Given this list of marker genes ERI2, DSG3, KCNK2, UPF1, TMED7, SIPA1L1, SNRPD3, BBX, SCX, AKAP5, EPS8, SEC23A, SRCIN1 (SRC kinase signaling inhibitor 1), C3orf70, TNFSF13B (NCBI Gene Id 89794), ERC2, VPS41, GUF1, AVL9, ANKRD17, RAB42, SCAI, DPY19L1, CDKN1B, MRPS23, NDST3, LINC03105, ZNF140, TENT4B (NCBI Gene Id 64282), DR1, RORA, RAB21, LRP1B, ARHGEF10, KCNH5, TYW5, KBTBD3 (kelch repeat and BTB domain containing 3), SS18L1, PPP3CB, ESS2, PTPRR, CNOT11, CD1E, FAM8A1, EXOSC3, HOMEZ, ZNF644, PIP4P2, UBE2D1, ANKRD27, KCTD15, MBOAT2, BDP1, RPA1, DCLK1, CRKL, TTC21B, DISP2, CAPN7, CASD1, PIGK, SMAD4, CTTNBP2, PHF6, SP3, BECN1, CNPPD1, PDE10A, LIFR, ARF4, C14orf93, SUPT6H, MKLN1, FSD1L, FGD4, GAN, CNTN3, GIN1, HORMAD1, YWHAE, SEC63, LINC03104 (long intergenic non-protein coding RNA 3104), BROX, CACNA2D1, SLC27A6, TSPYL5, PGM2L1, ALG2, SERTAD2, CHD2, ANAPC4, ZNF692, NKX6-3, PPA2, ARIH1, JADE1, ADD3, DISC1, HS3ST3B1, CCNO (NCBI Gene Id 9998), TLL1, ELAPOR2, RASGRP1, DNAI7, BRDT, ZDHHC21, HP1BP3, PACSIN2, TNPO1, LIG4, SPRYD7, GRM3, RPS16, RIC1, FAM120A2P, TMEM87A, INTS8, SLC7A11, TES, SYPL2, NPHP1, SOX7, HMGB3, RYK, EXOC4, PPP1R10, RPS6KA3, SNX18, CDK17, SF3B1, PNN, MAP3K20, ASCC1, GNPTG, COLEC12, WDR17, UBA6, DYRK1A, RIMKLB, ZNF621, ANK2, IGIP, LXN, MAPRE1, SEC61A2, NOC3L, OIT3, GABPA, GPR173, TENM1, NCOA7 (nuclear receptor coactivator 7), ELAVL4, GARNL3, CREB5 (cAMP responsive element binding protein 5), IMMP2L, MTMR6, SERINC1 (NCBI Gene Id 57515), SUMO3, NAP1L5, RNF139, ARMC10, AFF4, PKN2, PRKAR2B, GSDME, YIPF6, GJA1, MZF1, TIMP2, XKR8, BICD2, RBFOX1, DACT1, SMIM12, CTCFL, APBA3, NFIB, AGMO, TFAP2B, STAM2, PAQR9, TMEM232, SNAI2, VEZT, INKA2, BZW1 (basic leucine zipper and W2 domains 1), GPR75, CEP350, COMMD9, PLAG1, SRD5A3, NFE2L3, PURA, LAMC1, TMOD2, PTPRJ, XKR6, GALNS, LEF1, ANKS1B, ENSG00000277067, SIAH1, HAT1, PAN3, CCL23, FILIP1L, TIMP3, PLPP6, SULF1, SON, C5orf24, here is a description of the gene set: Human Gene Set: MIR892C_3P studied in species Homo sapiens Genes predicted to be targets of miRBase v22 microRNA hsa-miR-892c-3p in miRDB v6.0 with MirTarget v4 prediction scores > 80 (high confidence targets). from publication Chen Y, Wang X (PMID 31504780)